The following is a description of a gene set: Binds to and stops, prevents or reduces the activity of a protein serine/threonine kinase. Human Gene Set: GOMF_PROTEIN_SERINE_THREONINE_KINASE_INHIBITOR_ACTIVITY species: Homo sapiens, and this is the list of marker genes: INKA1, GSTP1, CDKN1B, PKIA, YWHAG, TRIB3, INCA1, SPRY2, CAMK2N2, PKIB, DEPTOR, HEXIM2, LRP6, CDKN2D, CDKN1C, PREX1, PRKAR2A, AKT1 (AKT serine/threonine kinase 1), CDKN2C, HSPA5, PKIG, PPP5C, RACK1, RPTOR, CIT, TESK1, HSPB1, ATAD3A, AKT1S1, PRKCH, PREX2, INKA2, SFN, PRKAR1B, PRKAR2B, PRKAR1A, MACROH2A1, KAT2B, PPP1R1B, SPRED1, PRKAG2, HEXIM1, HTRA2 (HtrA serine peptidase 2), SPRED2, PYDC1, SMO, CDKN2A, CAMK2N1, CDKN2B, PPEF2, CDKN1A, CASP3, ANKRD42, CIB1